Given this list of marker genes LAPTM4B, FURIN, GATA6, TYROBP, TSKU, CD2AP, here is a description of the gene set: Any process that stops, prevents, or reduces the frequency, rate, or extent of production of transforming growth factor-beta1. studied in species Homo sapiens Human Gene Set: GOBP_NEGATIVE_REGULATION_OF_TRANSFORMING_GROWTH_FACTOR_BETA1_PRODUCTION